Given this list of marker genes NHERF1, SLC19A2, SLC15A4, GRIN2A, MFSD2A, GRIN2B, SLC1A7, MFSD12, SLC47A1, SLC6A20, SLC16A12, SLC1A6, SLC25A12, SLC35D1, MPC1L, SLC27A6, SLC35D2, ABCC4, SLC25A15, SLC38A2, SLC26A4, SLC25A2, ABCD4, SLC38A5, GRIK5, SLC38A10, SLC1A1, ABCC3, SLC1A3, CTNS, SLC16A8, SLC51B (SLC51 subunit beta), SLC46A1, SLC6A6, SLCO2B1, SLC6A9, SLC23A2, SLC25A29, SLC16A5, ABCC11, SLC16A7, SLC7A3, SLC6A8, SLC5A12, SLC32A1, SLC17A8, SLC6A14, SLC23A1, SLC66A1LP, SLC26A3, SLC26A9, ABCD3, SLC36A4, SLC7A9, FABP3, SLC16A6, CD36, SLC25A38, SLC2A1, ABCG2, MPC2, SLC10A2, SLC16A11, GRIN1, SLC7A2, SLC27A1, SLCO1A2, SLC26A2, SLC19A1, SLC38A7, ABCB1, SLC16A4, SLC16A13, SLC26A10P, SLC5A8, SLC25A21, SLC25A26, SLC10A4, GRIN3B, SLC7A1, SLC27A5, SLC17A6, PDPN, SLC13A5, SLC25A11, SLC22A7, SLC27A2, MPC1, GRIK1, SLC3A2, SLC22A2, SLC6A13, SLC27A4, GRID2, SLC22A9, SLC38A11, SLC66A1, SLC38A9, FABP2, SLC7A13, GRIN2C, SLC25A10, AKR1C4, SLC25A18, SLC7A8, SLC7A7, UCP2, SLC7A6, SLC7A5, GRIA1, SLC16A9 (solute carrier family 16 member 9), TSPO2, SLC5A6, SLC1A4, SLC17A5 (solute carrier family 17 member 5), SLC38A6, SLCO1B1, GRIK2, SLC26A7, SLC10A5, SLC13A2, SLC25A32, FABP4, SLC16A10, SLC26A5, SLC38A3, SLC17A7, SLC3A1, SLC38A4, ABCB11, GRIA4, SLC10A1, SLC16A3, SLC26A1, SLC43A2, SLCO1B7, SLC38A8, SLC26A8, GRID1, SLC25A22, SLC6A11, SLC10A3, SLC22A13, SERINC3, GRIN2D (glutamate ionotropic receptor NMDA type subunit 2D), SLCO1B3-SLCO1B7, SFXN1, SLC43A1, ABCC2, GRIA2, SLC25A13, SLC7A10, SLC16A14, SLCO1B3, SLC16A2, FABP5, SLC1A2, SLC36A2, SLC6A1, SFXN5, SLC13A3, ABCC1, SLC22A6, SLC26A6, SLC10A6, SFXN3, GRIK3, SLC36A1, SLC29A4, SERINC5, SLC25A44, GRIA3, SLC6A7, SLC38A1, SLCO1C1, SLC36A3, GRIK4, SLC25A1, SLC6A15, ABCD2, SLC43A3, SLC7A14, SLC6A5, SLC7A11, SLC16A1, CEACAM1, GRIN3A, SLC1A5 (NCBI Gene Id 6510), ABCD1 (ATP binding cassette subfamily D member 1, NCBI Gene Id 215), SLC6A12, SLC51A, here is a description of the gene set: Human Gene Set: GOMF_ORGANIC_ACID_TRANSMEMBRANE_TRANSPORTER_ACTIVITY species: Homo sapiens Enables the transfer of organic acids from one side of a membrane to the other. Organic acids are acidic compound containing carbon in covalent linkage.